The following is a description of a gene set: The aggregation, arrangement and bonding together of proteins and a box C/D snoRNA to form a box C/D small nucleolar ribonucleoprotein (snoRNP) complex. studied in species Mus musculus Mouse Gene Set: GOBP_BOX_C_D_SNORNP_ASSEMBLY, and this is the list of marker genes: Nopchap1, Znhit6, Znhit3, Pih1d2, Nufip1, Ruvbl2, Pih1d1, Taf9, Snu13, Ruvbl1